Given this list of marker genes KCNA1, ZIC2, KCNJ3, SKP1, PPP3CC, ZNF140, ZBTB26, FGFBP3, CACNA1H, LANCL3, MASP1, SUDS3, TMEM33, XIAP, CNTN3, FAM114A2, CNOT6, KCNA4, NRXN1, MED23, HSPA12A, XIRP2 (NCBI Gene Id 440924), ZUP1, MAPK1, WNK4, SNX21, OSGIN2, DLAT, ARFIP1, TSR1, KRTAP4-3, ZSCAN21, EDNRB, CCDC117, ADCY9, CXXC4, UBFD1, MAX, VMA21, STC1, PDHA1, AZI2, STK39, API5, ARMC2, DMAC1, TBXA2R, LRRTM1, BCAT1, UNC5D, RB1, SHROOM3, KLF7, ALKBH2, KIR3DL2, CLIC5, HNF1B, FZD3, EBF1, RAB4A (NCBI Gene Id 5867), NEUROD1, RMND5A, ARB2A, HLA-B, C11orf87, ZNF148, PRPF40A, PAM, CXADR, NBR1, RNF139, DAZL, ATP11B, SCAF8, DOP1B (DOP1 leucine zipper like protein B), PPP1R1C, RBM22, TTC33, EYA4, ZBTB33, VASH2, CCDC6, here is a description of the gene set: Human Gene Set: MIR10B_3P from publication Chen Y, Wang X (PMID 31504780) studied in species Homo sapiens Genes predicted to be targets of miRBase v22 microRNA hsa-miR-10b-3p in miRDB v6.0 with MirTarget v4 prediction scores > 80 (high confidence targets).